Given this list of marker genes INHBA, SYNCRIP, RAB5IF, GPM6B, MRPL42 (NCBI Gene Id 64974), DIAPH3, CCDC80, ARHGEF18, RRM2, PRSS23, PSMD14, NDUFS6, MICOS10, PBK, EZR, KLF7, FLI1, TNPO1, PEA15, PSMD1, CHAC2, GLRX2, HLA-DRB1, TRIP13, MYH9, PODXL, MCF2, PUS1, SOX4, PHGDH, MTX1, DCTPP1, ABHD2, MICALL1, MCM5, PSMD2, PSMD12, SCHIP1, LIMS1, OGFOD1, ACOT9, PIGW, KPNA2, CENPM, SRXN1, NAA25, AATF, PSME2, AMY1A, NID2, ABCC10, LAMC2, CCNB2, CYGB, CDH11, CEP55, STAG1, CDK1, DPH3, ATP6V0D2, MRPL48, THBS1, VCAN, TUBB4B, F3, UBE2N, PHF19, MED27, BACE1, PMEPA1, TCF4, ITGB6, EMP1 (epithelial membrane protein 1), TUBA4A, BIRC5, DONSON, DTYMK, TUBG1, MRPL19, CENPU, KIFC3, ETS1, CMTM3, CSN2, N4BP2, LRRC8A, UBE2NL, CTPS1, TFB1M, UROD, CFAP91, ADAM19, ANO1, HSPE1, DERL1, PSMA4, TK1, GDF11, EIF2S1, TUBB2A, INVS, CTNNAL1, LINC01243, GPR39, TUBA1C, BOP1, HACD3, PSMA3, GPX2, NPLOC4, LAMA4, CENPW, HMMR, TNS4, MAP1B, CAV1, PTPRK, TPM1, PSMC2, TACC1, VCL, NPHP1, SUGT1, PALLD, PNP, DEFB106A, INF2, IDE, MGST1, NCAPG, PUF60, LTBP1 (latent transforming growth factor beta binding protein 1), GEMIN6, PIR, SLC35F2, HECTD1, AXL, POLE2, AKAP12, MFAP5, PSME3, PHB1, DCTN5, COPRS, RACGAP1, SMIM12, KRAS, LINP1, STUB1, USP6, HNRNPAB, PSMC3IP, MYCBP, UBE2D2, LINC00957, NICOL1 (NCBI Gene Id 401115), IFFO2, PSMC1, CLN8, PSMB2, SLC16A1-AS1, UBE2L3, IGFL1, QKI, HOXB9, MYEOV, STK17A, MRPL47, TGFBI, ITGBL1, DKK3, C9orf85, CCT2, TMPO, ATG3, CYP2B6, FERMT1, ITGB5, CALD1, ACOT7, RND3, ZBED2, TFPI2, GLIPR1, LRP4, FH, LRP8, CCDC85C, TMA7, CXXC5, NDUFAF8, PGLYRP4, PTTG3P, COL4A1, STX10, EBNA1BP2, NDUFS7, CENPV, PSMB4, FN1, PSMD11, HMGA2, CMTM7, EFEMP1, PGM2L1 (NCBI Gene Id 283209), AMIGO2, TPRKB, VSNL1, OCIAD2, KIF4A, RFC4, KNSTRN, LATS2, NUDT5, POTEKP, SHCBP1, PDF, FGF13, TTL, TUBA1B, NAA15, PSMA1, ATP5ME, RABEPK, LSM10, POP7, IL7R, TUBA4B, CENPX, NEURL1B, COX17, PGP, FBLIM1, DKC1, NOP2, COL1A2 (collagen type I alpha 2 chain), LINC00460, TIPIN, RPA3, IRAK1, NCAM1, MIX23, NET1, PSMA6, APOBEC3B, KRT7, ANAPC15 (NCBI Gene Id 25906), ARAP3 (ArfGAP with RhoGAP domain, ankyrin repeat and PH domain 3), HSP90AA1, LY6K (lymphocyte antigen 6 family member K), ADAMTS1, MLLT11, PELP1, EIF5, ME1, COL12A1, G3BP2, POMP, NME1, COL3A1, PA2G4P2, FST, AURKAIP1, F2RL1, NFATC2, ANXA3, RAD51C, LAMA3, IKBKG, TUBA1A, MMP2, ANKRD39, NIBAN1, CAV2, GPATCH4, GINS2, TRAPPC4, BDNF, CRIM1 (NCBI Gene Id 51232), FBXO44, DAAM1, ANAPC11, TUFT1, MRPL22, here is a description of the gene set: Using Affymetrix HG-U133 Plus 2.0 array and laser capture microdissection techniques, we determined whether different zones of the same pancreatic tumor exhibited differential expression of genes. Human L3.6pl pancreatic cancer cells were implanted into the pancreas of nude mice. Three weeks later when tumors were 7 to 9 mm in diameter, gene expression patterns in tumor cells within the central and peripheral zones were compared, and genes showed statistically significant differences. Bioinformatic functional analysis revealed that 346 up-regulated genes in the peripheral zone were related to cytoskeleton organization and biogenesis, cell cycle, cell adhesion, cell motility, DNA replication, localization, integrin-mediated signaling pathway, development, morphogenesis, and IkappaB kinase/nuclear factor-kappaB cascade; 876 up-regulated genes in the central zone were related to regulation of cell proliferation, regulation of transcription, transmembrane receptor protein tyrosine kinase signaling pathways, response to stress, small GTPase-mediated signal transduction, hexose metabolism, cell death, response to external stimulus, carbohydrate metabolism, and response to wounding. The reliability of the microarray results were confirmed by in situ hybridization analysis of the expression of two genes. Collectively, the data showed zonal heterogeneity for gene expression profiles in tumors and suggest that characterization of zonal gene expression profiles is essential if microarray analyses of genetic profiles are to produce reproducible data, predict disease prognosis, and allow design of specific therapeutics. studied in species Homo sapiens Up-regulated genes in peripheral zone of human pancreatic cancer growing in the pancreas of nude mice compared to that of the tumor from the central zone. from publication Nakamura T, Kuwai T, Kitadai Y, Sasaki T, Fan D, Coombes KR, Kim SJ, Fidler IJ (PMID 17699763) Human Gene Set: NAKAMURA_TUMOR_ZONE_PERIPHERAL_VS_CENTRAL_UP